The following is a description of a gene set: from publication Abbas AR, Baldwin D, Ma Y, Ouyang W, Gurney A, Martin F, Fong S, van Lookeren Campagne M, Godowski P, Williams PM, Chan AC, Clark HF (PMID 15789058) Immune cell-specific expression is one indication of the importance of a gene's role in the immune response. In order to identify such patterns, we set out to broadly profile gene expression in a variety of immune cells. species: Homo sapiens Genes up-regulated in comparison of naive CD4 T cells versus stimulated CD4 Th1 cells at 48 h. Human Gene Set: GSE22886_NAIVE_CD4_TCELL_VS_48H_ACT_TH1_UP, and this is the list of marker genes: ZBTB25, SRSF5, FOXL1, TSC1, ROR1, CARS2, PLEKHF2, MARCHF8, MANBA, TPCN1, KLF3, SREK1IP1, ABCA7, PBXIP1, MAU2, RPS24, STAT5B, LMBR1L, ERBIN, ZNF512B, FOXO1, ZNF318, LPAR2, RASA2, CLK4, CEP164, TMEM127, ATXN7L3B, ZBTB40, RETREG1, MSL1, NPIPA1, BTG2, CAMK2G, FAM169A, FOXJ3, TTN, LINC00342, MYH3, TRIM22, TES, ECHDC2, PXN, SETD1B, CLK1, HSPA1L, LDAF1, SCAND2P, RNF38, SP140L (NCBI Gene Id 93349), TESPA1, RPS20, PCIF1, RYK, ZNF862, MAP2K6, CD5, REPIN1, ZNF350, SPG7, ZNF91, BSDC1, LLGL2, RBM38, CCNL2, NAGPA, LIPT1, CTSL, USP34, ICAM2, IQSEC1, SVIL, PLCL2 (phospholipase C like 2), RASGRP2, RPS6, SNPH, ANKH, RPL32 (NCBI Gene Id 6161), TRIM44, IKBKB, ZNF148, DGKD, SMAGP, DCUN1D2 (defective in cullin neddylation 1 domain containing 2), RPS9, TP53TG1, IFIT5, ZNF609, RPL30, DENND1C, SLC35E2B, FAM117A, TMEM30B, LTBP3, TECTA, R3HDM4, TMEM8B, ACAP2 (ArfGAP with coiled-coil, ankyrin repeat and PH domains 2), NOSIP, TENT4A, ZMYM5, KRT18, PI4KA, BEX4, ZNF83, SEMA4C, IRS4, LYPD3 (NCBI Gene Id 94931), CD248, VPS13C, KLF9, TSC22D1, ZC3H3, EAPP, TBC1D4, FYB1 (FYN binding protein 1), SARAF, RNF44, FXYD5, PAIP2B, CLUHP3, FOXJ2, PRKCA, CHKB, LZTFL1, HLA-E, PTP4A3, SLC46A3, PRKD3, ZHX2, DLG1, ZFP36L2, ZNF136, VILL, NDST2, CFAP410 (cilia and flagella associated protein 410), SLC2A4RG, SYNJ2BP, TTC9, BCL7A, MMP8, MAP3K1, LEF1, MYLIP, ABCF3 (ATP binding cassette subfamily F member 3), NISCH, SH2B1, DBP, CCSER2, ATF7IP2, ZBED5, SPATA6, ATXN7, TSC22D3, ATP1A1, RETREG3, SF3B1, RPS27, RXRA, TAF1C, PRMT2, MSL3, ZNF652, MPO, RPLP1, BTG1, ECE1, VAMP1, HYAL2, OGA, PNISR, C11orf21, AMT, RASA3, USP33, UBE2G2, GABPB1-IT1, BTN3A1, NUMA1, SMPD1, FAU, CD55, SETD6, TSPYL2, SETX, TCF20, ATG14, LIPA, PLEKHA1, VIPR1, DUSP1, NKTR, PPFIBP2, IFITM1, PRKCZ, NLRP1, ZFP36L1, SYF2, SMARCE1, ZBTB14